Given this list of marker genes Alb, Ugt1a9, Ugt2a2, Ugt1a1, Cyp3a25, Acsm5 (acyl-CoA synthetase medium-chain family member 5), Cyp3a16, Cyp3a11, Cyp2d22, Ugt2b1, Ces2b, Ugt1a6a, Ugt2a3, Bsg, Ugt2b38, Glyat, Ugt1a7c, Cyp3a13, Ces1d, Ugt2b35, Acsm2 (NCBI Gene Id 233799), Ugt1a5, Ugt3a1, Ugt2b5, Ugt2b34, Slc22a7, Cyp3a44, Cyp3a41a, Ugt1a2, Glyatl3, Acsm4, Abcc2, Cyp2c66 (cytochrome P450, family 2, subfamily c, polypeptide 66), Ugt2b37 (UDP glucuronosyltransferase 2 family, polypeptide B37), Bche, Cyp2e1, Ugt3a2, Ugt2b36, Cyp2c65, Ugt2a1, Cyp3a41b, Slco2b1, Cyp3a57, Slc16a1 (solute carrier family 16 (monocarboxylic acid transporters), member 1, NCBI Gene Id 99768), Cyp3a59, Ugt1a8, Abcc3, here is a description of the gene set: studied in species Mus musculus Aspirin ADME Mouse Gene Set: REACTOME_ASPIRIN_ADME